Given this list of marker genes Pgk1, Pdia4, Dnajc10, Txndc2, AU015836, Txnrd1, Glrx2, Qsox2, Gsr, Ifi30, Coa7 (cytochrome c oxidase assembly factor 7), Coil, Tmx4, Txn1 (NCBI Gene Id 22166), Txn2, Gfer, Clic3, Txndc5, Ero1b, Tmx3, Gsto1, Txnrd3, Glrx, Nxn, Chchd4, Tmx2, Sco2 (NCBI Gene Id 100126824), Txndc17 (thioredoxin domain containing 17), Ero1a, Pdia6, Selenot, Txndc12, Txnrd2, Pdia5, P4hb, Pdia2, Txnl1, Gsto2, Qsox1, Tmx1, Pdia3, here is a description of the gene set: Mouse Gene Set: GOMF_DISULFIDE_OXIDOREDUCTASE_ACTIVITY Catalysis of the reaction: substrate with reduced sulfide groups = substrate with oxidized disulfide bonds. studied in species Mus musculus